The following is a description of a gene set: The chemical reactions and pathways resulting in the formation of any hormone, naturally occurring substances secreted by specialized cells that affects the metabolism or behavior of other cells possessing functional receptors for the hormone. studied in species Homo sapiens Human Gene Set: GOBP_HORMONE_BIOSYNTHETIC_PROCESS, and this is the list of marker genes: HSD3B1, DGKQ, SCP2, STC2, HSD17B8, CHST8, NR5A2, CYP11B1, CYP11B2, HSD17B1, DIO2, CHST9, ASMT, LHCGR (NCBI Gene Id 3973, luteinizing hormone/choriogonadotropin receptor), FFAR3, CYP19A1, CYP17A1, TSPO, ATP1A1, MED1, HSD17B3, SRD5A2, HSD17B7, FSHB, TG, HSD3B2 (NCBI Gene Id 3284), CLCN2, DHRS11, BMP6 (bone morphogenetic protein 6), HFE, CYP11A1, DUOX1, CACNA1H (calcium voltage-gated channel subunit alpha1 H), HSD17B12, PDE8B, SRD5A1, LHB, STARD3, DIO1, CYP21A2, AKR1B15, NR3C1, EGR1 (early growth response 1), AKR1B1, DAB2, BMP2, ADM, HSD17B11, ARNT, WNT4, HIF1A, FDX1, REST, AANAT, TPO, HSD17B2, RDH8, DKK3, BMP5, DUOX2, SRD5A3, H6PD, HSD17B6, DIO3, POR